Given this list of marker genes DNAH11, GLI2, EBF3, MCIDAS, TMTC3, LMBRD1, ARSL, CHD4, DNAJB13 (DnaJ heat shock protein family (Hsp40) member B13), RAI1, ERF, ZIC3, PIGN, DDX11, SPECC1L, CCNO, NAA20, FOXC1, DNAAF6, PEX1, KCNH1, DGCR8, ZMYND10, RNU4ATAC, PAH, ARF1, POLR1D, FKBP6, CSGALNACT1, RAD21, ARFGEF2, FGFR1, ERCC4, DNAH1, PIK3CA, MYCN, RSPH9, ANK1, SNRPB, ARID1B, SMARCC2, PSMD12, MMP14, VPS37D, FGFR2, FOXC2, POLR1C, LIMK1, PLCH1, MCTP2, GAS1, MYRF, BICRA, FBXL4, FLNA, PTPN22 (protein tyrosine phosphatase non-receptor type 22), OTUD5, DNMT3A, BMPR1A, SON, COQ4 (coenzyme Q4), PCNT, GP1BB, CCDC40, FOXF1, STRA6, HLA-B, ALG12, ANKS6, DNAH9, SOX11, GJA1, POGZ (NCBI Gene Id 23126), ZFX, RFWD3, FANCG, RPL5, EHMT1, TRRAP, ARHGAP31, PRDM16, DNAAF2, GATA5, BMP2, PORCN, MED12, EIF4A2, SMARCA2, MMP23B, DAW1, CEP120, ZMIZ1, COX7B, DNAI1, RPGR, ARID2, CREBBP, HIBCH, KMT2A, NEDD4L, FRA10AC1, TBC1D24, ATP6V1B2, DNAAF5, ZNF148, ZBTB7A, TMCO1, LZTR1, BAZ1B, WDR35 (NCBI Gene Id 57539), KCNN3, RAP1B, PIGL, MAF, USP18, DYNC2LI1, ABCC9, CFC1, B3GLCT, NADSYN1, GTF2IRD2, GLB1, KRAS, ZMPSTE24, DLL4, NIPBL (NCBI Gene Id 25836), PRKCZ, MFAP5, SRCAP, SMAD2, AXIN1 (axin 1), SMARCB1, BRCA1, FANCM, NME5, HDAC4, CDK8, DGCR6, ARL6IP6, MYLK, KDM6A, TTC12, RFC2, METTL27, VAC14, COL18A1, MKS1, ADAMTS10, RASA2, RAD51, TKT, GDF1, STX1A, SKIC2, CFAP221, ZEB2, UFC1, FUT8, CFAP300, SF3B2, EIF4H, NODAL, PTEN (NCBI Gene Id 8037), ARX, NSD1, UBE4B, TRAF7, FGF10, DNAH5, MEGF8, ZMYM2, EP300, RBPJ, KAT6A, SSR4, STXBP1, PDPN, DNAAF4, SMAD3, ZNF699, PAK2, NME8, RSPH3, TUBG1, GPC3, RBP4, PRDM13, FKTN, BRCA2, SOS2, DNAI2, SLC35A2, TRIO, ABCD4, SOS1, COA6, DISP1, MMP2, SPRED2, GATA4, TAB2, TBX2, FLT4, ZIC2, FOXJ1, EZH2, KMT2D, STK36, TBX5, TBX1, ODAD3, CBL, MYH7, MRAS, SPAG1, FANCE, ADAMTS17, DACT1, KANSL1, ESCO2, NKX2-5, C2CD3, WLS, MAP1B, SMC3, SLC37A4, GLYCTK, CDC42BPB, CASZ1, ZNF462, NONO, CDC42, THOC6, RBM10, CADM3, TGFB3, TALDO1, RSPH4A, MAPKAPK5, FBN2, MGAT2, GJA5, BRIP1, POLR1A, GTF2I, ODAD2, POLR1B, RPS26, SMARCA4, SMG9, KAT6B, RERE, MMP21, SF3B4 (NCBI Gene Id 171), RRAS, ADAT3, BPTF, AFF4, SAMD9, COG6, SNX14, LMNA, MAD2L2, NOTCH3, SUPT16H, FANCD2, WDR37, GLI3, HIRA, RAB34, TP63, GAS2L2 (NCBI Gene Id 246176), NOTCH2, HYMAI, NRAS, SOX4 (NCBI Gene Id 6659), SKIC3, SHANK3, ERMARD, CHD7, NXN, FTO, DNAAF11, WT1, PQBP1, RRAS2, HSPG2, ASXL2, TFAP2B, TGFBR1, BCR, CCDC39, ODAD1, MYH11, FANCI, SOX2, RREB1, CCDC22, WAC, HPGD, RAD51C, HEY2, PTPN11, TBL2, MKKS, OCLN, NKX2-6, LRRC56, ASCC1, GABRD, MAPK1, FGF8, CCDC47, SKI, TGFB2, KAT8, CXCR2, TGFBR2, AMER1, IGF2, SNRPN, KDR, MED11, AGGF1, SLX4, PLAGL1, ATP6V1E1, ZFPM2, SUCLG1 (NCBI Gene Id 8802), ACVR2B, TRIP4, DHCR24, GATA6, LOX, MAP2K1, THSD4, DTNA, AGO2, LMX1B, P4HA2, PCGF2, TGIF1, FANCL, ROR2, DPM1, ROBO1, FANCF, ATP2B1, MAP3K7, IGBP1, CEP295, MED13L, PIGT, IFT27, NPHP3, DYRK1A, CACNA1C, ALX3, DLL1, PRDM6, GNPAT, QRICH1, ALDH1A2, DOCK6, FBN1, RAF1, UBR7, NCF1, RPL11, MID1 (midline 1), CFAP53, DMPK, SLC25A24, HACD1, CHUK, DNAAF1, BRAF, TMEM270, KCNE5, CITED2, ARID1A, PKD1L1, STAG2, WASHC5, SH3PXD2B, CALM3, SIX6, EOGT, UFD1, PALB2, DVL3, CXCR4, VPS33A (NCBI Gene Id 65082), PTCH1 (NCBI Gene Id 8015), ARVCF, OFD1, TCOF1, RAC1, SLC29A3, INTU, PRIM1, DRC1, VPS35L, PACS1, MRPS16, SMC5, KMT2B, SMARCE1, LUZP1, MYOCD, CDON, HYDIN, YY1AP1 (YY1 associated protein 1), DHCR7, ESS2, SMARCD1, SIX3, SALL4, PPFIBP1, FOCAD, ITPR1, NIPA1, DGCR2, RSPH1, APC2, CTU2, ALG8, GNB2, UMPS, TMEM94, SPEF2, FIG4, ALX1, UBE2A, CTCF, JMJD1C, ACTA2, SALL1, BUD23, RBM8A, COMT, ACTB, PPP1CB, ALB, TBX4, DPF2, AMMECR1, UBE2T, PIGA, PHGDH, MAT2A, IFT56, EXT2, CIROP, CFAP298, THSD1, EIF2AK3, SUFU, FGFR3, NAA10, NEK8, CHRM3, TWIST1, CFAP74 (NCBI Gene Id 93196), FKBP14, CRKL, FANCA, DNAAF3, G6PC3, NIPA2, NR2F2, ELN, DNAJC30, GJA8, CLIP2, GPC4, SMAD4, DPYSL5, WDPCP, TRIP11, SPEN, FANCB, BCOR (NCBI Gene Id 57686), PLCB3, XRCC2, TMEM260, TSFM, FANCC, JAG1 (NCBI Gene Id 3715), RIT1, KYNU, STX5, FOXE3, DDX3X (NCBI Gene Id 730543), DDX59, TRPV6, SEMA3E, MASP1, DNAL1, FOXH1, HTRA2, LTBP2 (latent transforming growth factor beta binding protein 2), ODAD4, USP9X, IPO8, PLXND1, ACSL4, EED, NEK10, PUF60, WBP4, NOTCH1, CUX1, SIK3, PRKG1, CD96, SEC24C, SHH, NCAPG2, PEX19, LARS2, FOXP2, KCNAB2, RSPRY1, GNA11, CRIPTO, KCNJ8, GTF2IRD1, RAB23, ECE1, HLA-DRB1, NFIX, here is a description of the gene set: Human Gene Set: HP_CONGENITAL_MALFORMATION_OF_THE_GREAT_ARTERIES species: Homo sapiens Defect or defects of the morphogenesis of the aorta and pulmonary arteries. Congenital malformation of the great arteries